The following is a description of a gene set: Binding to a phosphorylated serine residue within a protein. Human Gene Set: GOMF_PHOSPHOSERINE_RESIDUE_BINDING studied in species Homo sapiens, and this is the list of marker genes: YWHAB, SCAF8, SCAF4, LEO1, YWHAZ, PCIF1, SFN, NEDD4, YWHAE, PIN1